The following is a description of a gene set: Pathway Definition from KEGG: TAX -| CDKN1A -| (CDK2+CCNE) -> RB1 // E2F Human Gene Set: KEGG_MEDICUS_PATHOGEN_HTLV_1_TAX_TO_P21_CELL_CYCLE_G1_S_N00498 species: Homo sapiens HTLV-1 Tax to p21-cell cycle G1/S. Pathway ID: N00498. Pathway type: Pathogen. Pathway class: nt06160 Human T-cell leukemia virus 1 (HTLV-1)., and this is the list of marker genes: E2F1, CDKN1A, CDK2, E2F2, CCNE2 (cyclin E2), E2F3, RB1, CCNE1